Given this list of marker genes S1pr3, Lpar3, S1pr5, Plppr3, Lpar5, Plppr1, S1pr4, Lpar2, Plppr5, here is a description of the gene set: studied in species Mus musculus Reactome Pathway: Lysosphingolipid and LPA receptors part of: Class A/1 (Rhodopsin-like receptors) This event has been computationally inferred from an event that has been demonstrated in another species.<p>The inference is based on the homology mapping from PANTHER. Briefly, reactions for which all involved PhysicalEntities (in input, output and catalyst) have a mapped orthologue/paralogue (for complexes at least 75% of components must have a mapping) are inferred to the other species. electronically inferred by orthology from the curated human pathway